The following is a description of a gene set: from publication Gavish A, Tyler M, Greenwald AC, Hoefflin R, Simkin D, Tschernichovsky R, Galili Darnell N, Somech E, Barbolin C, Antman T, Kovarsky D, Barrett T, Gonzalez Castro LN, Halder D, Chanoch-Myers R, Laffy J, Mints M, Wider A, Tal R, Spitzer A, Hara T, Raitses-Gurevich M, Stossel C, Golan T, Tirosh A, Suvà ML, Puram SV, Tirosh I (PMID 37258682) species: Homo sapiens Human Gene Set: GAVISH_3CA_METAPROGRAM_CD4_T_CELLS_DYSFUNCTION Genes upregulated in subsets of cells of a given type within various tumors In this study, an extensive analysis was conducted to define meta-programs (MPs) capturing intra-tumor heterogeneity across a spectrum of tumor types. The approach utilized non-negative matrix factorization (NMF) to analyze each cell type separately within individual tumor samples. This involved the analysis of malignant cells, macrophages, fibroblasts, endothelial cells, epithelial cells, T-cells, and B-cells. NMF was executed with varying parameter values (K=4, 5, 6, 7, 8, 9), thereby generating 39 programs for each cell type per sample. Each NMF program was summarized by the top genes based on NMF coefficients.\nRobust MPs were then delineated for each cell type using a set of stringent criteria, including recurrence within the same tumor, similarity to programs in other tumors, and non-redundancy within a tumor. Subsequently, these robust NMF programs were clustered (per cell type) based on Jaccard similarity, leading to the identification of MPs associated with each cell type.\nTo enhance the quality of the MPs, a refinement steps were undertaken, involving the removal of MPs suspected of reflecting low-quality data (with an overrepresentation of ribosomal proteins or mitochondrial-encoded genes), single-study inclusion, or similarity to miss-annotated cell types., and this is the list of marker genes: PDCD1, SMCO4, SESN1, YWHAQ, NMB, CHN1, ALOX5AP, THADA, CD40LG, BTLA, CD84, SFXN1, KLRB1, SLA, NAP1L4, CORO1B, RBPJ, TBC1D4, ITM2A, MAGEH1, TIGIT, SH2D1A, BBLN, DUSP4, AKAP13, AHI1, CD200, TNFRSF18, PVALB, RGS2, NR3C1, IL6ST, PASK, TOX2, CHI3L2, FABP5, RNF19A (NCBI Gene Id 81036), TSHZ2, PPP1CC, NUDT16, CXCL13, ICA1, TCF7, LIMS1, FKBP5, MAF, COTL1, TOX, CPM